The following is a description of a gene set: Human Gene Set: MODULE_455 species: Homo sapiens Genes in the cancer module 455., and this is the list of marker genes: MEF2C, UFSP2, FOXRED1, MAPK8IP2, DPYSL5, BEX4, KRT17, MSI1, GDA, SYT13, NRCAM, TACSTD2, RAP1GAP, RUNX3, C8orf34, MREG, RHOU, RALGAPB, COLEC12, DYNC2H1 (dynein cytoplasmic 2 heavy chain 1), CABP5, ABCC2 (ATP binding cassette subfamily C member 2), KRT19 (NCBI Gene Id 3880), GPRASP2, MX2, ANXA9, ACP5 (acid phosphatase 5, tartrate resistant), MXI1, PHF12, TPSAB1, PKIB, MMP25, PACS2, NKD2, SPON1, NHSL1, CSTA, UNC13A, COQ4